The following is a description of a gene set: studied in species Homo sapiens Human Gene Set: chr2q21, and this is the list of marker genes: CCDC115, RNU6-1132P, ENSG00000229797, UBXN4, KLF2P2, POTEI, CYP4F62P, RPL19P4, NCKAP5-AS1, RHOQP2, POTEJ (NCBI Gene Id 653781), YBX1P7, FAR2P2, POTEF, MED15P3, MTND1P29, MTCYBP10, MTCO1P18, CYCSP8, NCKAP5-IT1, ARHGEF4, AMER3 (APC membrane recruitment protein 3), TUBA3E, G3BP1P1, MTCO2P18, PRSS40A, RNA5SP104, RNU6-473P, CCNT2-AS1, POTEE, RNU6-127P, RAB6D, MED15P8, MTND6P8, KLF2P3, RAB6C-AS1, LCT, ENSG00000295763, MTCO1P7, MAP3K19, NF1P8, RAB6C, ARHGAP42P1, RNU6-175P, RN7SKP93, LINC01087, ARHGEF4-AS1, POTEF-AS1, RNU6-1049P, RPL22P7, IMP4, MCM6, ANKRD30BL, CDC27P1, GRAMD4P8, MTND1P26, MTND2P22, NBEAP2, SSBP3P2, MZT2A, RNU6-579P, MTND3P18, MZT2B, MIR128-1, MED15P9, MGAT5, MED15P4, MANEALP1 (NCBI Gene Id 391448), ZNF285CP (zinc finger protein 285C, pseudogene), MTND6P10, FAR2P1, DARS1, PLEKHB2, SSBP3P6, ARHGAP42P2, MIR5590, PRSS40B, MTND5P29, MTCO3P18 (MT-CO3 pseudogene 18), NCKAP5, MIR663B, LINC01945, RHOQP3, LINC01856, SMPD4, POTEKP, CCDC74B, CCNT2, SNORA40B, MTND3P15, GPR39, ENSG00000290654, NEK2P4, ACMSD, ENSG00000281516, R3HDM1, PLAC9P1, MTND5P23, CFC1, LYPD1, KLF2P1, TEKT4P3, SMIM39, LINC02572, CCDC74A, MED15P5 (mediator complex subunit 15 pseudogene 5), VDAC2P4 (NCBI Gene Id 100420574), LINC01854, CDRT15P4, DARS1-AS1, NOC2LP2, FAR2P4 (fatty acyl-CoA reductase 2 pseudogene 4), TUBA3D, MIR3679, ZRANB3, MTCO2P7, NCKAP5-AS2, RN7SKP103, RN7SKP154, GPR148, PPIAP65, LCT-AS1, FAM168B, SMPD4BP, MTATP6P7, TOMM40P4, CYP4F27P, MTND2P18, RNU6-512P, LINC01120, MTND4P21, BNIP3P46, MTND4P27, CFC1B, MTCYBP8, FAM201B, KLF2P4, NOC2LP1, RAB3GAP1, GNAQP1, CYP4F30P, MTATP6P4, EDDM3CP, RNA5-8SP5, RNU6-617P, LINC03124, FAR2P3, RNU6-848P, MIR4784, PTPN18, MTCO3P7, CDRT15P3, TMEM163